Given this list of marker genes GALNTL6, ZNF8, HOXD3, PGRMC2, FGL1, BCL11A, VCL, EMB, SNHG8, ABLIM1, GOLGA1, STK17A, ADD3, COA1, RABGEF1P1, EEF1B2, TES, MRPL48, AUTS2, MAN2B1, KBTBD7, FXN, TCF3, TAFA1, CELSR2, ZMPSTE24, NACA, CCDC78, PKP2, PRMT5, TNFRSF1A, TNFAIP8L1, ARHGEF16, MID1IP1, NFIA, CALHM6, BAG3, CACHD1, IL17RA, KY, ADA2, FGFBP2 (fibroblast growth factor binding protein 2), TTLL11, ACVR2A, NR2C2 (NCBI Gene Id 7182), SNX27, TPM2, S100A13, PTGDS, PUS1, TIMM9, EEIG1, IFT20, CTSC (NCBI Gene Id 50958), ANOS1, IGSF11, KLHL24, CARMIL1, PRDM16, AOAH, CHCT1, GGPS1, CBLIF, ID2, MAP3K12, CEPT1, ZNF131, NIPAL3, TMEM259, MYL3, FN3K, EBF1, CHD7, TYSND1, RPS3A, CARNMT1, LIPA, LAMC3, H1-10-AS1, CHI3L2, UIMC1, GZF1, ZNF830, LRWD1 (leucine rich repeats and WD repeat domain containing 1), NDUFB3, ADPRM, GZMA, PPP1R2, ITPKA, NHSL3, CR2, EARS2, POLG2, PTK2, ERMP1, NELL2, PITPNC1, SMAD6, HK2, INPP4A, INTS9, FZD10-AS1, RPL7L1, RING1, TSEN2, NOLC1, TPT1-AS1 (NCBI Gene Id 100190939), PCBP2, PRKAR1B, TMIGD2, MTUS1 (NCBI Gene Id 57509), ZNHIT6, SEMA4D, BORCS7, SNHG32, LARS1, RRAS, C12orf76, ULK2, ZNF800, RPL5, APBA2, TARS3, PDCD4-AS1, TOB1, PDIA5, RPAIN, CAPS, NUP43, ZNF287, SSX2IP, RNASE6, C11orf54, PRMT2, SUN5, CDK8, TMEM39B, SCML1, TCF7L2, SNRNP48, PLIN2, LGALS8, DDX55, NDUFB2-AS1, CLCN5, LDHA, POU6F1, MAST3, KAT2A, PLLP, AK2, ADA, SIAE, PKIG, RHOBTB3, NPAT, NAB1, DYRK2, DLL1, MRFAP1L2, KRT35, PAICS, UBAC2, SLC46A2, IFNAR1, TRIT1, SLC25A23, SNHG28, DENND2D, SH2D4A, MRPL18, GATD1, SNHG16, HAND2, LINC01128, SRPRB, SFSWAP, PDK3, SPESP1, CZIB, SYNJ2BP, HEATR3, ST6GALNAC1, CAMK4, RHPN1-AS1, TRMT61B, AKAP8, COX18, SPATA9, PTGDR2, CDK5RAP1, UQCRH, OCIAD2, ADGRL1 (adhesion G protein-coupled receptor L1), XRN2, here is a description of the gene set: Human Gene Set: GSE25087_TREG_VS_TCONV_FETUS_DN We compared differences in fetal and adult T cells by performing whole genome profiling on sort-purified T cells (naïve CD4+ and Treg cells) from human fetal specimens (18-22 gestational weeks) and adult specimens (age 25-40 years old). Fetal and Adult Naïve CD4+ T cells phenotype: CD3+CD4+CD45RA+CCR7+CD27+, Fetal and Adult CD4+CD25+ Treg phenotype: CD3+CD4+CD25bright from publication Mold JE, Venkatasubrahmanyam S, Burt TD, Michaëlsson J, Rivera JM, Galkina SA, Weinberg K, Stoddart CA, McCune JM (PMID 21164017) species: Homo sapiens Genes down-regulated in comparison of fetal regulatory T cell (Treg) versus fetal conventional T cells.